The following is a description of a gene set: species: Homo sapiens from publication Hay SB, Ferchen K, Chetal K, Grimes HL, Salomonis N (PMID 30243574) Human Gene Set: HAY_BONE_MARROW_DENDRITIC_CELL, and this is the list of marker genes: DUSP5, PAPLN-AS1, SLC20A1, B4GALT1, SMPD3, FUT7, SLC15A4, EGLN3, SCAMP4, KCNK17, ALOX5AP, PLD4 (phospholipase D family member 4), CUX2, OPN3, PLP2, ABCA15P (NCBI Gene Id 400508), ZFAT, C12orf75, HLA-DQA1, CACNA2D3, SCAMP5, SERPINF1, NOPCHAP1, SLC9A7, C1orf54, DNAJC4, RHEX, SFT2D2, CUEDC1, CLN8, CYP46A1, LINC02812, WDFY4, CIB2, JAML, FAM221B, SEMA7A, LINC01724, SNX3 (sorting nexin 3), CSF2RB, TGFBI, HLA-DPA1, CADM4, GAPT, SLC4A3, UPK3A, LAMP5, SSR1, PPIB, PTPRS, GNA15, PROC, CCDC88A, NDRG2, SUSD1, PPM1J, UBE2E2, RUBCN, TNFRSF21, NEK8 (NIMA related kinase 8), EIF2AK4 (eukaryotic translation initiation factor 2 alpha kinase 4), SCT, LSP1, CLEC10A, LINC00865, ATG101, KCNK10, MILR1, ITM2C, SMIM6, TM9SF2, CLIC2, ALCAM, IRF7, IDH3A, BRK1, SEC61B (SEC61 translocon subunit beta), EPHB1, IL3RA, KCNA5, HLA-DRA, KRT5, SLC35F3, TPM2, SIDT1, COL26A1, ANKRD65, OSTC, SERPINF2, PHACTR1, CFAP119, PTMS, HLA-DQB1, CSF2RA, MAPKAPK2, MRC1, PLAC8, PKIB (cAMP-dependent protein kinase inhibitor beta), SHD, P2RY14, PLXNA4 (NCBI Gene Id 91584), EPHA2, IRF8, HLA-DPB1, SPCS1 (signal peptidase complex subunit 1), CCDC183, CCDC50, GRIP1, KCNK6, SCN9A, OFD1, LILRA4, SPNS3, CST3, AP3S1, CRIP3, IL1R2, CBFA2T3, PRXL2A, PLVAP, HLA-DMB, HLA-DRB1, ALDH2, ASIP, MYBL2, NUDT17, TXN, RRBP1, PFKFB2, CD74, COMT, CRYM, KIRREL3, RPS6KA4, NLRP7, ARID3A, MAP1A, CD1C, PHEX, FCER1A (NCBI Gene Id 2205), VEGFB, CD2AP, CIITA, SPINT2, DNASE1L3, LILRB4, UGCG, PPP1R14B, TMEM210, LCT-AS1, GPR183, SLC12A3, PARK7, TSPAN13, LINC00996, RUNX2, PALD1, LRRC36, UNC93B1, CBX6, LGMN, TNNI2, PON2, HLA-DRB5, APP, PACSIN1, ST3GAL4, TMED10, ERCC1, LRRC26, TMEM8B, P2RY6, SLC7A5 (NCBI Gene Id 8140), PPP1R14B-AS1, SEC61G, CXCR3, VASH2, SLC7A11, TCF4, TMEM109, SH3BP4, NOTCH4 (NCBI Gene Id 4855), ENHO, CD1E, HLA-DMA, PARVG, TRAF4, TTC39A, MIF4GD, ST14, HLA-DQA2, CLEC4C (NCBI Gene Id 63328), RNASE6, BCL11A, LINC02132